The following is a description of a gene set: Human Gene Set: GOCC_MITOCHONDRIAL_MATRIX The gel-like material, with considerable fine structure, that lies in the matrix space, or lumen, of a mitochondrion. It contains the enzymes of the tricarboxylic acid cycle and, in some organisms, the enzymes concerned with fatty acid oxidation. studied in species Homo sapiens, and this is the list of marker genes: PRDX5, MTERF1, SUOX, HADHA, ACSF2, ATP5PB, PRIMPOL, DHFR2, MGME1, RNASEL, PUS1, HSD17B8, ACSM3, BCKDK, MDH2, MTHFD2L, NDUFB8, FAHD1, HYKK, AKR1B15, ABCE1, MRPS31, MRPL47, EARS2 (NCBI Gene Id 124454), MIPEP, ISCA1, MRPS26, LRRK2, TOP3A, DDX28, MRPL10 (mitochondrial ribosomal protein L10), TRUB2, BTD, ACO2, AURKAIP1, ETNPPL, MRPL46, MRPS5, POLG, PRODH, PARG, MRPS24, POLG2, FXN, AGXT2, KARS1, BCAT2, ALDH7A1, TTC5, UQCC2, NAGS, MECR, MRPL20, ACSS2, OAT (ornithine aminotransferase), MTNAP1 (mitochondrial nucleoid associated protein 1), MRPS18A, LIPT2, MRPL4, CREB1 (cAMP responsive element binding protein 1), NUDT1, PDHA1, EXOG, PDPR, MT-CO2, NME4, SUCLG1, MRPL22, FASTKD5, NIPSNAP2, LACTB2, BLOC1S1, CBR4, ATP5F1B, CYP11A1 (NCBI Gene Id 1583), METTL8, PRKACA, MRPL52, POLDIP2, GSTK1, MTHFD1L, THEM5, ARHGAP11B, SHC1, MRPS30, MRPL45, HADH, ACSM2A, NDUFA9, MRPL38, METTL17, MRPL33, ALDH6A1 (aldehyde dehydrogenase 6 family member A1), PPA2, PABPC5, DHRS2, MRPL54, ATP5F1D, LIPT1, ACOT11, BCO2, ACADVL, MPG, TMLHE, ACOT9, GRPEL1, ETHE1, NUBPL, GARS1, PIF1, ALDH5A1, GUF1, NT5M, ABHD11, ME3, PAM16, HTD2, LDHAL6B, NSUN4, FTMT, TWNK, HIBCH, FDX1, SARS2, FASTKD2, ISCA2, PYCR1, DLST, CHPF, DLD, ARL2, LRRC59, CDK5RAP1, PDK4, RARS2, MRPL23, ME2, MRPL2, HPDL, NDUFS3, PHYKPL, ERBB4 (erb-b2 receptor tyrosine kinase 4), ECH1, TK2, MRPS9, FPGS (NCBI Gene Id 2356), SHMT2, ETFA, DARS2, NR3C1, OTC, ACSS1, PDHB, ECHS1, BCL2L1, RCC1L, ANGEL2, MRPS28, PCCB, PITRM1, TYMS, OGDHL, ERAL1, ATG4D, NUDT2, MRPS11, CA5A, PCK2, DLAT, TFB2M, TXN2, ACSM2B, FECH, HARS2, RPS3, TRAP1, MRPL19, PIN4, MRM2, PMPCA, MTRF1L, ALDH1B1, MRPL57, DHX30, DAP3, MRPL14, ETFBKMT, CSKMT (NCBI Gene Id 751071), CMC1, RAD51, VDAC1, COQ5, GLRX5, NDUFS8, MRPL3, MRPL16, NAT8L, MRPS22, SDHAF2, HSPE1, MRPS14, ACSS3, NRDC, LARS2, SDHB, TIMM44, PCCA (propionyl-CoA carboxylase subunit alpha), DGUOK, PDK3, FASTK, ALDH2, TRMT10C, HINT2, PDE2A, NDUFS1, ACACB, CLPX, GLDC, PRORP, UQCRFS1, ATAD3A, OXA1L, ACADSB, ACSF3, STYXL1, MRPS25, MRPL32, C2orf69, TST, MTCO2P12, MTHFS (NCBI Gene Id 10588), MRPL40, ATP5F1A, ALAS2, FASTKD3, FDXR, TBRG4, SLC25A5, MRPL21, MRPL15, PYROXD2, POLRMT, DGLUCY, MRPL13, HAX1, MTG1, GOT2, MRPS34, DHTKD1, MRPL50, CDKN2A, IDH3G, ACAT1, MTERF3 (NCBI Gene Id 51001), NFU1, AASS, MAIP1, TP53, MCCC2, GLS, PARK7, ACAD10, ACADM, PARS2, MRPL49, RIDA, CDK1, PTPN1, MRPL55, HSPD1, PDE12, SUCLA2, ELAC2, HSD17B10 (NCBI Gene Id 50828), MRPL9, ALAS1 (NCBI Gene Id 211), AADAT, ATP5F1E, ACOT13, ACAA2, MRPL35, ATXN3, NARS2, GPT2, HAGH, IDH3A, GSR, SOD1 (superoxide dismutase 1), AK4, PPM1K, MMAA, MRPS6, NUDT9, SDHAF1, GLUD1, GLUD2, YARS2, MRPS33, FLAD1, HSPA9, NDUFAF7, PGK1, MTRFR, ALDH1L2, SLIRP, MRPL34, AK3, ECI1 (NCBI Gene Id 1632), MRPL43, NFS1, PDHX, TP53AIP1, CCNB1, PNPT1, CCAR2, MRPS15, ACADL, RTN4IP1, DMGDH, MRPL18, HMGCS2, MRPL51, ATP5F1C, FH, CPT2, PDP1, PDP2, MRPL12, MRPL48, SMDT1, NGRN, RNASEH1, MRPS27, MTERF4, LIG3, OGG1, NMNAT3, CASQ1, PDK2, MRPL41, MRPS18C, MRPL42, TERT, MLYCD, NDUFAF8, MARS2, EXD2, MPST, MRM1, CPS1, MCAT, IBA57, MTRES1, MRPL11, MRPS23, SUCLG2, TUFM (Tu translation elongation factor, mitochondrial), BCKDHB, DBT, FDPS, ACOT2, TARS2, SDHAF4, NDUFAB1, MRPL24, MRPL37, TFAM, SSBP1, ABHD10, FOXO3B, HOGA1, PRDX3, NDUFAF1, TRNT1, FASTKD1, ACP6, DNAJC15, IARS2, MYG1, PDSS2, AUH, YWHAG, ABAT, FDX2, CA5B, CS, AMT, NME6, GSTZ1, TRIT1, HIBADH, CYP27A1, ETFB, REXO2, NUDT13, GCSH, OXCT1, MRPS7, LIAS, RPUSD3, ALDH18A1, SOD2, ALKBH7, ACSM1, NADK2, MRPS16 (NCBI Gene Id 64959), HADHB, ACSM5, MRPL53, D2HGDH, MRM3, THEM4, ARG2, VDAC2, MTG2, GFM2 (GTP dependent ribosome recycling factor mitochondrial 2), METTL15, SIRT3, NAXD, SDHA, ADPRS, OXCT2, PPTC7, MALSU1, DNA2, MRPL17, MRPS17, MRPS21, ALDH4A1, COASY, TRMT5, MRRF, SNCA, FARS2, LONP1, SUPV3L1, MTHFD2, PDK1 (pyruvate dehydrogenase kinase 1), IDH2, IVD, NDUFS2, C1QBP, PTCD1 (NCBI Gene Id 26024), GCDH, SDHAF3, PPIF, POLQ, GLYAT, MCEE, ADHFE1, MRPL1, LYRM4, MRPS12, TOP1MT (NCBI Gene Id 116447), TRMT2B, GRPEL2, FOXO3, HMGCL, CLPP, PDHA2, QARS1, RPUSD4, SPATA18, LYRM7, STAR, MRPS18B, TFB1M, TRMT61B, GPX1, ISCU, CHCHD1, METTL4, GLS2, DNAJA3, COX10 (cytochrome c oxidase assembly factor heme A:farnesyltransferase COX10), IDH3B, PTCD3, NSUN3, MRPL58, MRPL39, COQ3, MRPL28, GADD45GIP1, NAXE, NGB, OGDH, MCCC1, PMPCB, MRPS35, MRPL27, PDSS1, GRSF1, MRPS2, WARS2, DNAJC19, NDUFA10, DUSP21, MRPL36, ACSM4, SIRT4, ACADS, ACAD8, BCKDHA, SARDH, ARL2BP, OXSM, MRPL44, MMUT, TEFM, BDH1, TXNRD2, SIRT5, MIURF (NCBI Gene Id 127898561), ACSM6, MMAB, GFM1, BOLA3, LRPPRC, DECR1, NDUFS7, PC, MRPL30, NIPSNAP1, MRPS10, MTERF2